Given this list of marker genes AEN, SNX9, ANKRD20A1, KLRA1P, AP1G2, CD164, ORAI2, DHX15, ARL8B, STARD4, SYNE2, C12orf43, FYTTD1, CRKL, PELI1, DNAJC5B, WSB1, MARCHF6, STK10, WDR75, LBR, APOA2, GLCCI1, NOC3L, NFKBID, DDX49, TLE4, STK4, FMNL1, TAF1D, HLA-DRB3, KLF10, FEM1A, OGA, P2RY8, NSUN2 (NCBI Gene Id 54888), SGCD, LPP, CRIP2, SEC16A, UBR7, PPTC7, THOC7, IRS2, MIOS, TACC1 (transforming acidic coiled-coil containing protein 1), DBF4, RNGTT, SBNO1, RAB8B, PTPN11, AGO2, BET1L, LIPA, CD69, EAF1 (ELL associated factor 1), C1orf159, PPP4R3B, G3BP2 (NCBI Gene Id 9908), SNRNP200, PMAIP1, KLHL15 (NCBI Gene Id 80311), INSIG1, TAGAP, ZMIZ2, NUP205, PKD1, HOXA7, ULK4, NR4A2, EIF2AK3, NMD3, C2CD5, LBH, MUS81, ANKRD44, INTS7, KBTBD8, NOX4, TRAK1, here is a description of the gene set: species: Homo sapiens Human Gene Set: MODULE_358 B lymphoma expression clusters.